Given this list of marker genes SERPINF2, CDHR5, CYP4F12, TAT, G6PC1, CES1, APOC2, ASGR2, SLC22A1, HMGCL, CYP2E1, CYP2A6, CPN2, SDS, PON1, MAT1A, CYP4F11, ORM1, AKR7A3, APOC1, GAMT, TMPRSS6, C6, ITIH1, ATF5, VTN, HAAO, GJB1, DCXR, ALDH4A1, HSD17B6 (hydroxysteroid 17-beta dehydrogenase 6), ECHS1, RDH16, APOC3, SLC38A3, CYP1A2, F10, HPD, PEMT, FTCD, SLC10A1, UPB1, SERPINC1, GSTM1, CES2, ORM2, HPX, GNMT, F2, SAA4, GSTM2 (NCBI Gene Id 82152), F12, SLC22A7, ASL, CYP27A1, C8A, RARRES2, ITIH4, AGXT, ADH1C (alcohol dehydrogenase 1C (class I), gamma polypeptide), CYP2D6, PXMP2, ALDH1L1, MASP2, CEBPA, HAMP (hepcidin antimicrobial peptide), PON3, SERPING1, GALK1, PCK1, CYP2C8, SERPINA4, PROC, AMBP, SARDH, ZGPAT, ABCC6, FAH, APOA1, C8G, APOF, TKFC, KHK, PIPOX, TST, TMEM176B (NCBI Gene Id 28959), ANGPTL8, CIDEB, APCS, IGFALS, SERPIND1, CYP2C9, RBP4, ITIH3, ANG, NNMT, HPN, CYP4A11, LCAT, GSTZ1, ACOX2, HP, HGFAC, HRG, HMGCS2, APOC4, CYP4F2, TMEM176A, SLC27A5, here is a description of the gene set: Human Gene Set: GNF2_GSTM1 studied in species Homo sapiens Neighborhood of GSTM1 Neighborhood of GSTM1 glutathione S-transferase M1 in the GNF2 expression compendium